Given this list of marker genes GPD1, SLC4A4, IGF1, LDHA, GIT1, EP300, PRKAG2, MFSD8, INS, LIPA, ARL2, INSR, PNP, PRKAA1, HKDC1, PFKP, ACTN3, GALK1, ENO1, NUDT12, SRC, OGDH, HK2, FOXK1, PSEN1, JMJD8, TIGAR, HIF1A, QPRT, IFNG, DHTKD1, ALDOA, UCP2, DDIT4, ARNT, ENO2, ENO3, TREX1 (three prime repair exonuclease 1), ZBTB7A, NCOR1, SLC2A6, FOXK2, IER3, PRXL2C, FKRP, PFKM, ALDOB, TRIM63, ZBTB20, UCHL1, FBP1, HDAC4, P2RX7, MTCH2, STAT3, GAPDH, PKLR, MTOR, MLXIPL, PDXP, HK1, PFKL (phosphofructokinase, liver type), FLCN, COL6A1, PGAM1, PFKFB2, GAPDHS, PGAM4, PFKFB3, PGM1, ENO4, CBFA2T3, EIF6, ADPGK, NUDT17, MTAP, ALDOC, BPGM, SLC4A1, PRKACA, GCK, APP, HTR2A, PKM, PPP2CA, KAT2B, GPI, MLST8, PGK2, HK3, OGDHL, PPARA, PFKFB1, RPTOR, PRKAG1, OGT, SARM1, NUPR1 (nuclear protein 1, transcriptional regulator), PRKAA2, SIRT6, NUDT13, TPI1, BCL2L13, PGK1, PRKAG3, PGAM2, here is a description of the gene set: The chemical reactions and pathways resulting in the breakdown of a pyridine-containing compound, i.e. any compound that contains pyridine or a formal derivative thereof. Human Gene Set: GOBP_PYRIDINE_CONTAINING_COMPOUND_CATABOLIC_PROCESS studied in species Homo sapiens